Given this list of marker genes APOC1, MRTFA, OXA1L, SNORA26, IBTK, NEAT1, TIMM13, MT-TD, DNAJB5, ULK4, CORO7, DEPDC5, CCNT2, ILRUN-AS1, DBP, IQCD, NXPH3, MT-RNR1, WDR55 (NCBI Gene Id 54853), ADAM17, HCG25, ATM, JMY, MT-TN, C9, MT-TQ, TP53INP2, MT-TM, BRWD1, CEP350, GRAMD1B, SAFB2, RB1CC1, RSRP1, MT-ND6 (mitochondrially encoded NADH:ubiquinone oxidoreductase core subunit 6), ZC3H18, MT-TY, MT-TF, MT-CO2, DOT1L, CCNG2, PGBD4, OBSL1, BCKDK, UQCC4 (NCBI Gene Id 283951), FAAHP1, SH2D6, PMS2CL, MT-TC, EP400P1, MT-ND2, SAFB, UPF2, TMCO6, ADGRG3 (adhesion G protein-coupled receptor G3), EEF2, JUN-DT, UNKL, ENSG00000272008, SMARCD1, LINC01410, EIF4E, GTF3C1, DENND6A-DT, ZNF292, MT-TW, DENND4B, COQ10A, DAB2, ZNF780B, AMBRA1, HCP5, EXOSC9, CCNT2-AS1 (NCBI Gene Id 100129961), MT-CO1, NPAT, JUN, TXNDC11, GRM7-AS3, MT-TT, INHA, LHFPL5, FDX2 (ferredoxin 2), EIF3E, PNISR, CLUL1, DENND6A, MT-TA, PALM, SMG1P2, MIR4449, DNAJA3, FGGY, MT-TI, HMGN2P34, GXYLT1, EMC7, APH1A, TMEM41B, MT-CYB, OXA1L-DT, DANCR, H1-4, GSTA4, SLC25A35, MT-TE, HBP1, BORCS7, SERGEF, CASC3, here is a description of the gene set: from publication Yevshin I, Sharipov R, Kolmykov S, Kondrakhin Y, Kolpakov F (PMID 30445619) Human Gene Set: THRA_TARGET_GENES studied in species Homo sapiens Genes containing one or more binding sites for (THRA) in their promoter regions (TSS -1000,+100 bp) as identified by GTRD version 20.06 ChIP-seq harmonization.